The following is a description of a gene set: Mouse Gene Set: GOMF_D2_DOPAMINE_RECEPTOR_BINDING species: Mus musculus Binding to a D2 dopamine receptor., and this is the list of marker genes: Dnm1, Ppp1r9b, Gnai1 (G protein subunit alpha i1), Ppp1r1b, Grin2b, Dnm2, Clic6